Given this list of marker genes Adcy1, Adcy4, Lhcgr, Gnal, Raf1, Adcy2, Adcy3, Adcyap1, Calca, Acr, Drd1, Adcy7, here is a description of the gene set: Any process that initiates the activity of the inactive enzyme adenylate cyclase. Mouse Gene Set: GOBP_ACTIVATION_OF_ADENYLATE_CYCLASE_ACTIVITY species: Mus musculus